The following is a description of a gene set: studied in species Mus musculus Mouse Gene Set: MIR_1291 from publication Chen Y, Wang X (PMID 31504780) Genes predicted to be targets of miRBase v22 microRNA mmu_miR_1291 in miRDB v6.0 with MirTarget v4 prediction scores > 80 (high confidence targets)., and this is the list of marker genes: Adpgk, Dyrk1a, Adam12, Max, Jarid2, Neurl4, Agrn, Wsb1, Elovl6, Dach2, Ctsc (NCBI Gene Id 13032), Slc9a8, Ube2q2, Mia3, Aadacl3 (arylacetamide deacetylase like 3), Srp54b, Map2k6, Emp1, Nras, Phf20, Adipor2, Itpr1 (inositol 1,4,5-trisphosphate receptor 1), 0610040J01Rik, Lbr (NCBI Gene Id 98386), Tsc22d2 (TSC22 domain family, member 2), Anp32a, Bcl2l2, Trh, E2f4, Dnajc16, Optc, Inpp4b, Sycp1, Rnf152, Zfp35, Adcy1, Plcxd1, Mtmr2, Slc25a15, Pds5b, Rnf14, Cdh10, Slc39a10, Styk1, H2bw2, Pdxk, Gbf1, Foxc1, Eif2d (NCBI Gene Id 51958), Clock, Nr5a2, Cyp4a12a, Gcsam, Ccdc50, Htt, Ubxn7, Gabrg2, Cnot4, Anp32b, Pkdcc, Kmt5b, Edem3, Tpgs2, Rassf1, Zhx3, Lrrtm2, Rab7, Birc6, Rictor, Selenoi, Kcnj16, Cyp4a12b, Parp14, Cacna1d, Spmip2